Given this list of marker genes Dnase2a, Cltb, M6pr, Ap1s3, Ap1g2 (NCBI Gene Id 11766), Chmp2a, Dnm2, Ap1s1, Bloc1s1, Ap4s1, Clvs2, Ap1b1, Dnajc6, Vamp2, Vamp8, Arf1, Ap1m1, here is a description of the gene set: studied in species Mus musculus electronically inferred by orthology from the curated human pathway This event has been computationally inferred from an event that has been demonstrated in another species.<p>The inference is based on the homology mapping from PANTHER. Briefly, reactions for which all involved PhysicalEntities (in input, output and catalyst) have a mapped orthologue/paralogue (for complexes at least 75% of components must have a mapping) are inferred to the other species. part of: trans-Golgi Network Vesicle Budding Reactome Pathway: Lysosome Vesicle Biogenesis